Given this list of marker genes Cdyl2, Glra2, Cds2, Foxp2 (NCBI Gene Id 72715), Usp10, Pam, Med13, Atp13a5, Pcdha5, Pcdha6, Fam47c, Clptm1, Coa5, Cuedc2, Pcdha12 (NCBI Gene Id 192164), Pcdha9, Trak2, Larp4, Ppp3r1, Fcho2, Pcdha3, Ret, Ssh2, Trio, Rag1, Crkl, Ctsl, Zfp960, Tcf12, Stxbp5l, P2ry12, Ptchd3, Arl4c, Arid4b, Pcdhac2, Ociad1, Ube3a, Atxn1, Gm9, Taf4b, Pcdha10 (protocadherin alpha 10), Rbm27, Pcdha2, Apc, Nptx1, Pramel7, Pcdha11, Ywhaz, Fignl2, Pcdha4, Deptor (DEP domain containing MTOR-interacting protein), Rgs7bp, Mbd4, Eri1, Sarnp, Tom1l2, Zfp935, Pcdh9, Pcdhac1, Gm3636, Gspt1, Adcy9, Rimoc1, Zfr, Rab2a, Spg11, Map2, Siah1a, Pcdha1 (protocadherin alpha 1), Baz2b, Ahsa2, Senp8, Lipf, Ino80d, Ube2b, Zmym4, Asxl1, AI182371, Pcdhb14, Ifih1, Lrrtm2, Relch (RAB11 binding and LisH domain, coiled-coil and HEAT repeat containing), Cdr2, Zmynd11, Wdr43, Tmem144, Pcdh15, Fut8, Pla2g2f, Pcdha7, Ctse, Rab6a, Itgav, Dcstamp, Tpp2, Tmem9b, Arih1, Zfp97, Xpo1, Crh, Snap25 (NCBI Gene Id 57077), Fam53c, Ubl4a, Pou5f2, here is a description of the gene set: from publication Chen Y, Wang X (PMID 31504780) studied in species Mus musculus Genes predicted to be targets of miRBase v22 microRNA mmu_miR_881_3p in miRDB v6.0 with MirTarget v4 prediction scores > 80 (high confidence targets). Mouse Gene Set: MIR_881_3P